The following is a description of a gene set: Human Gene Set: CAGCTG_AP4_Q5 from publication Xie X, Lu J, Kulbokas EJ, Golub TR, Mootha V, Lindblad-Toh K, Lander ES, Kellis M (PMID 15735639) Comprehensive identification of all functional elements encoded in the human genome is a fundamental need in biomedical research. Here, we present a comparative analysis of the human, mouse, rat and dog genomes to create a systematic catalogue of common regulatory motifs in promoters and 3' untranslated regions (3' UTRs). The promoter analysis yields 174 candidate motifs, including most previously known transcription-factor binding sites and 105 new motifs. The 3'-UTR analysis yields 106 motifs likely to be involved in post-transcriptional regulation. Nearly one-half are associated with microRNAs (miRNAs), leading to the discovery of many new miRNA genes and their likely target genes. Our results suggest that previous estimates of the number of human miRNA genes were low, and that miRNAs regulate at least 20% of human genes. The overall results provide a systematic view of gene regulation in the human, which will be refined as additional mammalian genomes become available. studied in species Homo sapiens Genes having at least one occurrence of the highly conserved motif M15 CAGCTG in the regions spanning 4 kb centered on their transcription starting sites. This matches the REPIN1 transcription factor binding site V$AP4_Q5 (v7.4 TRANSFAC)., and this is the list of marker genes: ZNF593, TNNI2, BMP6, ZFP36L1, MARK2, RUNDC1, AP3D1, SBSN, DLEU1, ZFYVE1, AQP5, FZD9, ARF4, TMEM104, CD72 (NCBI Gene Id 971), NPHP4, ATP1B4, MRGPRF, SLC35A4, ZBTB20, CD99L2, CLEC4D, LRRN2, CAST, ATXN7L2, MAN2B1, MEGF10, RPUSD4, MYCLP1, TBCC, ABHD16A (abhydrolase domain containing 16A, phospholipase), FOXS1, MUSK (muscle associated receptor tyrosine kinase), ERH, ANXA8, HDAC4, HCFC2, MT1E, SOX10, GRIN2D, PKD2L1 (polycystin 2 like 1, transient receptor potential cation channel), SKIDA1, NDUFA4, ACMSD, CELA3A, LINC01567, LENG9 (leukocyte receptor cluster member 9), ADCY4, CREM, NSG2, GPX1, MYH13, IL11, KLF10, PURA, BRSK2, SNN, HIP1R, NR2E1, LEMD2, DHRS3, FAM222A, RAB3A, LY6G6E, BRINP1, KCNN2, MYO1C, NAGLU, ARPP21, ITSN1, SGK2, PYGM, MITF, RNF14, KCNH2, PPP1R7, NXPH3, MAP3K13, DLL4, HIVEP3, DLGAP1, RAB33A, CNTN4, CELF3, EGR1, SPEG, USP13, PTPN6, STAT3, CTXN1, APOA5, LNX1, ACTN3 (actinin alpha 3), CAVIN2, ST8SIA4, NEURL1, SEMA6D (NCBI Gene Id 80031), TMEM182, HMOX1, CA3 (carbonic anhydrase 3), IGF1, GREB1L, ITGA6, PRICKLE2, WDR83, FXYD3, RENBP, TP53INP2, UBE2B, AGBL5, CNTN6, BTBD3, ATP6V1C1, MYCBP, SLC39A9, FXR1, PCYT1B, SRP54 (signal recognition particle 54), PRMT6, DTNA, GRIK3, IL11RA, ERN1, TNNC2, RYK, ARHGAP44, NTS, NOTCH1, WNT10B, FREM1, EMILIN3, IRAG1, EGR2, MOSMO, HTR3A, CLEC14A, ZMYND8 (zinc finger MYND-type containing 8), ASB16, DPF2, LBX1, ASB2, BACE2, NID2, LRRN1, ITGB1BP2, MAST1, DDIT4L, TMEM86A, SLC4A1, EBNA1BP2, LONRF1, ITGA3, USP32, AZIN1, FOXO4, IGFBP3, FOXP1, LINC00670, TXNDC12, TSC22D4, SYTL2, BNIP3, ZNF385A, YWHAZ, PAK3, DOCK6, PAM, YY1AP1, KLF13, MAPRE3, ZNF703, PATL1, DYSF, CPA6, PLS3, SCFD1, MORC3, TRIM8 (tripartite motif containing 8), LRRN3, APBA2, FCGBP, PLCB2, JAG1, FAM110A, FAM193A, E2F1, RBFOX1, FHL3, C1QTNF1, TNKS1BP1 (tankyrase 1 binding protein 1), GTPBP2, SRD5A3, TPM3, NXPH4, HSPB6, AMER1, ARID1A, HSPB2, SEZ6, CTSD, LINC02875, UBR5, MXI1, OLFML1, PCDH18, FOXD3, DCLRE1A, TMUB2, SPOP, HOXC6, DRP2, KMT2A, WDTC1, MSS51, SEMA7A, H2BC3, MYO1F, FBXO40, RHOBTB2, PPP2R5E, FGF17, TGIF1, DUSP26, MPRIP, GOLGA7, ALK, SLITRK6, ARHGAP45 (NCBI Gene Id 23526), SUPT16H, DPH1, ZFYVE26, IGFBP6 (NCBI Gene Id 3489), NTF4, BBLN, BCL6B, HJV (hemojuvelin BMP co-receptor), SYNRG, TXN, TUBB2B, ZFAND3, CFAP65, CDK2, SYT6, WNT6, CYTH3, AFG3L1P, TAS1R1, S100A2 (S100 calcium binding protein A2), ZNF384, SPRED1, CSMD3, BAZ2A, GRPR, PIGN (phosphatidylinositol glycan anchor biosynthesis class N), PSIP1, LRBA, EYA1, ERP27, RPS6KB1, HTR5A, ZNF326, TINAGL1, RAD51B, ADCY8, GPR37L1, TCF12, WNT2, ACTA1, SLC35C2, CLVS1, CRHBP, NDRG1, MYL3, PCF11, CDKN3, CDX1, MAP3K8, LGI4, LMF2, PTK7, ENO3, ANKZF1, PRKAG3, NBEA, CREB3L1, BTG2, ESCO1, ID3, DPP3, SCRN1, TBC1D2B (TBC1 domain family member 2B), ESRRA, SERPINE1, MASP1, DNHD1, GPM6B, NGF, IP6K3, GNB3, SULT2B1, CNP, WNK4, NR4A1 (nuclear receptor subfamily 4 group A member 1), DOC2A, AKR7A2, ZEB2 (NCBI Gene Id 9839), COLEC12, MYO18A, PRKCB, CACNG2, SLC25A41, LTBP1, ATP6V1E2, MOSPD1, HMGA2, PARP12, PAK5, TPMT, NFIX, ZBTB16, SNPH, LGI3, LGSN, LRRN4CL, SHISA6, RNF121, CD247, REPS1 (NCBI Gene Id 85021), TNFSF4, ZNF232, DMPK, PPAT, MCF2, NCDN, TMEM125, CDK5R2, BMPR2, SPRY4, HOXA6 (NCBI Gene Id 3203), SH3BP1, PADI2, YBX2, HID1, IFNL2, PAICS, NAT9, LHX2, RAD51D, RPL28, C11orf87, CARMIL3, SLC1A7, CDC25B, TAPT1-AS1, PODN, P2RY4, HIGD1B (HIG1 hypoxia inducible domain family member 1B), GAS7, REEP6, RIMS1, NEB, ARHGAP33, DPP9, BACH2, SLC38A3, NTF3, KLK2, NLGN3, HIP1, WNK2 (WNK lysine deficient protein kinase 2), ABR, VXN, COA3, PRDM8, DLL1, SEMA4A, ANK2, OGG1, TONSL, CABP1, SLC25A26, ARHGAP8, GABPB2, EIF2S1, PASK, STAT2 (signal transducer and activator of transcription 2), FILIP1, YARS1, F11R, RNF216, SLC5A10, FOXA1, KLHDC7A, ZMYM2, ATF7IP, DDX5 (DEAD-box helicase 5), PPM1J, HSH2D, XBP1, ABHD4, PDGFB, GPR62, APLN, GCAT, TRIP11, NOVA1, EXOC6, MIR9-1HG, RGS8, HOXD10 (NCBI Gene Id 3236), CRMA, ANXA6, JMJD1C, CCL4, STAT5A, ARL6IP5, CNTN2 (contactin 2), CUL7, RTKN, SLC8A3 (NCBI Gene Id 90450), KDM2A, S100A3, CMKLR1, IL17B, SRF, CALM3, ZBTB25 (zinc finger and BTB domain containing 25), LRRK1, OGFOD2, KSR2, TMEM35A, SEPTIN4, PCDH9, PHKA1, PIK3CG, TIMP4, WWC2-AS2, ADAMTS8, ERBB3, MANBA, OSR1, HNRNPDL, UBALD2, HOXA3, PGF, MAF, FER1L6-AS1, CCL27, MYL6B, ANKRD12, SYNPO2L, IL10, FLRT3, TUBA8, INHA, MYT1, MID1, IRX4, SH2D6, EPHA2, IL24, ADAMTS4, MYOZ1, SH2B3, PDZD11, PRKACG, CDH6, NR4A3, SCAP, PDE1A, GPD1, KCNJ16, SYVN1, ATP1B2, KCNJ13, PLN, PLEC, MYF5, RAB24, OMG, CORO2B, ETV5, HOXC4, LDLRAD3, NECTIN3, DALRD3, ATP4A (ATPase H+/K+ transporting subunit alpha), FBXO36, HHATL, KCNS3 (NCBI Gene Id 3790), CMKLR2, NOL4, UBE2W, PTH1R, CDKN2C, PLAAT3, ZNF398, PLEKHA6, EIF4ENIF1, UNC119, C7, PBXIP1, CLDN15, KCNMB3, GAP43, TTLL7, HHEX, MGLL, RAPSN, ZNF646, NANOS1, GIGYF2, RAI1, PPP1R17, PSD, SLC12A8, FAM98A, QTRT2, TSC22D3 (NCBI Gene Id 64477), MRPL14, RNF166, KCNQ5, PROSER3 (NCBI Gene Id 148137), LUC7L3, OMA1, L1CAM, WDFY1, TRMT10A, PDHA2, MAP2K5, TBX3, DOCK9, RNF213, SYT16, VEGFA, RABAC1, MATN1, ARMC8, ZNF277, KLHL1, RTN2, SELPLG (selectin P ligand), MTIF2, CDC42SE1, PTGDS, SPPL3, POLD4 (NCBI Gene Id 57804), COL7A1, TCF7, MFNG, MUC15, PHF7, ZSWIM8, ABL1, TNNT3, RIBC2, ZNF777, SCUBE3, CITED2 (Cbp/p300 interacting transactivator with Glu/Asp rich carboxy-terminal domain 2), RELA, LGI1, AGAP2, NDUFC1, GPR174, LCK, AAK1, MED13, SCN4A, B3GALNT2, GNG3, SMARCA2, HRAS, CHID1, ASPA, SMAP2, SPATA31H1, TGFB3, MYADM, RIPOR1, MTSS1, TSPAN33, EN1, RGS6, DRG1, NUDT22, TAL2, ELF4, MYO18B, SRPX, BCL11B, DES, GFI1, MAN1C1, GRHL3, PEX7, MYBPC1, RGR, DDIT4, VEZF1, TRIM39 (tripartite motif containing 39), E2F3 (NCBI Gene Id 1871), ZMIZ1, XIRP1, DDX17, ADGRL3, CERKL, RHBDF1, PLPP7, LINC00487, PPP3CB, RUSC1-AS1, SAMTOR, KCNMA1, MYCN, RASSF2, ADGRG4, WDR25 (WD repeat domain 25), TNNT2, RASSF1, TNFRSF19, SLC44A2, TGFBR2, EPCIP, TMOD4, BEST2, CLPS, RAB27A, AKT2, RRAD, GABRA3, FBXO24, YTHDF2 (NCBI Gene Id 63042), FGF14, EXTL1, TRAPPC3, FAM120B, FGF12, NCKAP5, TENT5C, KLF5, ELL3, CAPZA3, SLC22A17, C6orf47, IMPDH1, TRPV1, REEP1, FBXL21P, USP1, TMEM126B, CCDC138, UBE2H, SCT, GEM, OPCML, GPR162, SUPT5H, FMO5, SLC4A2, TRIT1, CEP95, RFX8, LBX2-AS1 (LBX2 antisense RNA 1), ASS1, GPR21, NRG2, TOLLIP, MID2, GOLGA2P11, TFAP4, SYNC, COX6A2, NDUFAF3, FAM193B, SLF2, HPSE2, RPL23AP32, NTNG2, RTL9, CIBAR2, CHRNA1, HTR2C, ANKRD1, SRCIN1, NRK, RUNX3, FITM1 (fat storage inducing transmembrane protein 1), FGF7, STOML2, IL1RAPL2, CBFA2T3, PDE3A, RAB5B, ELAVL2, TRERF1, INF2, GPBP1, GJC2, MTMR10, VAT1, TOB1, ABTB3, ASIC2, PVALB, KCNIP3, PITX3, ATP2B3, EPOR, ABLIM1, CNNM2, ANGEL1, SOX2, TRAF3, LOXL4, B3GALT2, APBB3, ONECUT2, SPECC1, GATA1, ZMAT3, NCAPH2, GRIN2B, ARFGEF1, DLG2, HYAL2, ARHGEF6, TGFB2, CDHR5, FEZF2, CSF1R, RAP2B, COMMD3, ZNF710, PLCZ1, SLITRK5, LRCH4, MDK, WNT9A, PAX1, KCNQ4, FIS1, SV2A, GOLM2, DACT1, CHPF, MARCHF1, SPINK5, IDH2, MAP2K6, NDST4, NAPEPLD, TPCN1, CDKL5, POU4F1, HS3ST4, HSD3B7, JPT1, NEDD4, CALCOCO1, LHFPL1, TFAP2C, BTF3P11, TUBA4A, ACSL4, SEPTIN3, RASGEF1A, MAPK4, RTRAF, EOMES, PEPD, LNX2, TNS1, DCX, GPR34, KCNA2, MARCHF5, CD79B, ZNF521, HMGN2, KLF8, SMARCA1, NDUFA4L2, CCDC43, SOX4, GADD45G, INSR, MAP1A, SSX2IP, ATG9A, SPIB, PARP8, ADAMTSL2, ID1, NKX2-2, CLDN2, DLEU2, TMOD3, SLC44A1, WBP1L, SPG21, TRIP4, ZBTB18, LINC03124, VSTM2A, PRICKLE1, LARP4, TRIM46, DYNLRB2, HES6, RAG1, DOK7, RRAGD, SPTAN1, CLIP1, KDM4C, FOXN2, RCOR2 (REST corepressor 2), KCNQ1DN, ERF, PHF23, HDAC9, LRP5, STXBP6, FAM131A, MAPK8IP1, ERLIN2, SGMS2, FGF13, TMEM25, MLIP, DAO, PNMA1, DUSP1, SOST, USF1, IFNL3, SMARCA5, ZMYM4, PPP1R9B, NHSL2, NUMBL, SRRM3 (NCBI Gene Id 222183), TPM2, MLLT11, TLNRD1, PDE7A, LINC01089, VWA5A, APOBEC2, TMEM17, PTCH2, IRF2BPL, PLXNB3, WNT4, NRBF2, SALL1, MCAM (NCBI Gene Id 4162), CASKIN2, KRTCAP2, SKA2, MBNL1, PLEKHA4, SMG5, CDKN1B, LAMA5, USO1 (USO1 vesicle transport factor), PRR30, AKT1 (AKT serine/threonine kinase 1), PTGFRN, BMF, PAK6, ALS2, SCN5A, GSK3B, BSCL2, TMEM184A, PLP1, OR2L13, WDR83OS, ADO, KLF12, H3C4, CA11, ATP6V1D, IMPG1, RUNX1T1, RAD51AP1, RERG, PEG10, IPCEF1, PDK2, EDC4, NEUROG3, RAB3C, CCDC78, WDPCP, DLL3, SPTBN1, TNNT1, UBE2O, ESRRG, TRIM54, CKM, AP5M1, PPP1R16B, TUBA1A, CDH3, TRPC4, MTMR4, SVIL, SMIM43, NAP1L5, HSPA5, PARP6, RCAN1, HSPB3, SIX5, IQCD, CACNB1, SOWAHA, ATP5PD, UFM1, PACSIN3, ABCB9, YPEL5, ARHGEF5, ETV1, MEF2C, CHAC1, PHF1, LINC00482, CDH13, CMTM5, UBTF, EPN2, ACE, MYBPH, BNIP2, CNTNAP5, RBMS3, VGF, ACTB, COL5A3, SMC1B, CHRNG, MOB3C, NDST2, PLAC1, TSEN54, DTX3, RDH10, CCDC65, ARHGAP24, APBB2, TMF1, ELAVL3, CILP, AQP2, CCDC186, PDLIM2, MEIS2, STIM1, SPTY2D1, RESF1 (retroelement silencing factor 1), LDLRAD4, GRK2, PTP4A3, XPR1, MPPED2, TMEM178A, SLC30A8, PTCHD1, SOBP, TPI1, NNAT, LHX3, DNAJC1, S100A8, MYL11, PRKACA, AIF1L, PPP2R3A, KCTD8, RNF19B, HDAC11, RARA, DMC1, PDLIM4, LGALS1, ISL1, MYOT, MAP3K5, BAP1, PSD2, MDM2, SPCS1, H2AZ1, STAR, CCNJ, CAMK2G, SMARCAL1, SLC66A1 (NCBI Gene Id 54896), HIF1A, CADM2, SAMD1, METTL8, EIF4G2, TRIM62, CCDC85B, CD276, CDO1, VAMP1, TENM3-AS1, ETS1, ACTC1, FGF8, RBM15B, KLK13, AKAP9, RHOD, VAMP3 (NCBI Gene Id 9341), PPP2R5C, HSD11B1, NIPBL, PRR35, TUSC2, ARMC5, EPN3, LRCH1, PIK3AP1, NOL9, KIRREL2, TMEM255A, NUDT18, NCF4, COL2A1, KCNN3, BORCS5, H2AC7, CAMKV, KRT19, APPBP2, DCAF17, RIN1, KIF4A, USP49, LHFPL2, CASK, ACVR1, TEX35, GRK5, STAT5B, CNIH2, ZNF503, KNCN, ART1, SLC1A4, CFAP57, EYA3, CUTA, MSTN, RETNLB, LIMK2, GATA3, CRACR2A, RNF13, SLC7A11, CYP2F1, DMD, AFF4, TRPM4, ZNF267, ZBTB33, MYOZ2, MYOZ3, SORBS3, TCF21, ETF1, PCBP4, WNT10A, VPS18, TLE4, AMOT, IZUMO4 (NCBI Gene Id 113177), BNC2, FCER1G, BRINP3, FGF1, FES, GASAL1, PSMD3, COL22A1, AARSD1, APOLD1, SLC29A4 (NCBI Gene Id 222962), SLC5A7, NAV1, BRD4, TMEM105, MEF2D, SPOCK2, PHLDB1, PRKCQ, CHD4, SLC43A3, NAA50, SLC18A3, PRPF39, TFDP2, ELN, MAGED1, CXXC4, TAFAZZIN, INA, MYPN, RASL10B, REPS2, RUFY1, DBNDD1, PDAP1 (PDGFA associated protein 1), UGT1A7, IGF1R, BCL7A, MAP3K3, GNB2, TPPP3, CBFA2T2, SUV39H2, RGS7, DAAM1, H2BC7, PTGIR, PREX2 (phosphatidylinositol-3,4,5-trisphosphate dependent Rac exchange factor 2), CRYAB, SMYD1, ARNT, INKA1 (inka box actin regulator 1), KLHDC2 (kelch domain containing 2), BAHD1, PML, VGLL3, BAIAP2, TMEM100, MIR137HG, ROBO4, KCNJ2, OBSCN, SH3BGRL3, ANP32A, GPR17, DLX1, RXRG, ZNF133, DENR, FBXO5, BEND4, IL34, CACNA1S, MINDY1, LUC7L, SLC12A2, FGR, MCOLN1, TEAD2, KIF7, RAB26, NACA, WBP2NL, SGCG, PRRG2, GZMB, BEX2, EYA2, ELP4, BACH1, DVL3, FCRLB, PRR14L, SOX5, BCL9L, SPAG6, ALDH1A1, ARHGEF2, LRRTM1, ITGB8, PTK2, CNTD1, ESR1, USP5, SRPK3, TUBB4A, NPPA, MBP, CD47, LRRTM3, SLC26A10P (solute carrier family 26 member 10, pseudogene), LEF1, SUMO2, MYLK, KCNIP2 (potassium voltage-gated channel interacting protein 2), TMEM109, MMRN2, IMMP1L, PRDM13, SPATA6, KLHL40, SOX12, ANGPT1, KLHL41, WNT2B, ANKRD20A11P, POLL, KCNK5, CATSPER2, POLR3GL, APOD, TUG1, CSNK1G2, CPEB3, STMN2, VAMP8 (vesicle associated membrane protein 8), MEGF8, CCDC26, HOXB1, CCDC102A, MOS, TRAF4, SUMO4, NOL4L, USP32P2, MYH4, EFNA1, CRB1, CAV3, CACNA2D3, NADK2, MYO7A, NR5A1 (NCBI Gene Id 2516), P2RX4, PRR11, PTPN1, LRFN5, FERRY3, HOXB5 (homeobox B5), ABTB2, PTPRS, TUBA4B, HSD17B8, FCRLA, GGNBP2, ATP13A4, ALPK2, MACROD1, FAM50A, LINC00299, ZNF513, RASGRF2, CRIP2, SGIP1, SYTL1, KCNE4, EPHB2, CRCT1, LURAP1L, ORMDL3, NDNF, LMOD3, FGF21, FAM217B, CDK18, RUNX1, SHOX2, NUTF2, WNT8B, WNT7B, BCL2L2, PABPC5, CSDE1, TCF4, CALCA, LOXL1, C11orf52, GAB2, FAAP100, MOG, ACTG2, ESRRB, TBX6, SPIN2A, STAC3, PJA2, MIR22HG, LDB3, ITPR3, LINC00303, RUFY4, ABCE1, USP3, MFRP, NEXN-AS1, SRC, XCL2, DSCAM, ATP6V0D1, DNAJA1, TGIF2, USP54, EDF1, LTA, XPNPEP1, DPCD, UNC45B, ANGPT4, CHFR, KIF1B, TNRC6C, TRPT1, CACNB2, LINC02872, TNNC1, TOR1AIP1, ATP6V1A, THPO, RYR1, NEUROD2, DBH (dopamine beta-hydroxylase), C6orf62, PRKCG, DDR1, CACNA1H, CADPS, CLSTN2, MIR1-1HG, PPM1A, APBA1, STARD13, RIT1, CPS1, MBNL2, FRAS1, NAV3, CCDC177, ROCK1, PALMD, ATP1A2, PROK2, MAGI1, SYT17, EXTL3, WDR81, JPH1, RBBP7, LRP1, PMEL, BCAS3, CD9, FNDC8, DEPTOR, PI4KB (phosphatidylinositol 4-kinase beta), SLC6A14, CPEB4, RORC, CXorf58, SET, IKZF2, LMO4, CDK5, INPPL1, TP53BP1, SHISA4, FNDC5, SNCG, RNF111, OTUD7A, GNG8, LAT, CYP46A1, ELL, DCTN1, HAPLN2, P2RX5 (purinergic receptor P2X 5), LINC01138, H1-0 (NCBI Gene Id 3005), CACNA1G, HRC, DLC1, BICRA, CHRNE, MYC, EXOC5, AICDA, CCNE2, NOSIP, GSDMA, ATOH8, RGS12, LAMB2, HECTD2, HOXD3, RAMP2, RBM14, SLC24A3, ZNF668, GDNF, DNAJB5, PCBP2, KLK1, AP1S2, C7orf33, ASB5, GPR61, TUBG2, HOXA5, CHAT, RSRC1, EDN3, MAN1A1, TMT1B, SEPTIN7, POLR1D, CDCA3, IER5L, HPCA, DUSP4 (dual specificity phosphatase 4), DERL3, MLYCD, BMP1, ADGRB3, NES, TMEM79, MYBL2, ZRANB1, ANGPTL2, ABI2, VPS45, PDE10A, RBFOX2, NHLH2, DOCK4, NKD1, TMEM8B, CASKIN1, KCNS2, RCSD1, SCAMP5, APOO, HOXC12, DMTF1, FLNC, NEDD4L, GHR, LINC01931, ANK1, RPA3, KIFC3, HOOK1, CDC42EP3, DOK3, RASL10A, NR3C2, SERF2, ADAMTS2 (ADAM metallopeptidase with thrombospondin type 1 motif 2), PMP22, SSC4D, CCDC71, P3H3, CDK2AP1, WBP4, RAB30, ZCCHC24, EMP3, UBE2K, PAX2, PICALM, BFSP2, SCN3B, SORBS1, EFS, MYH3, CYP8B1, C1orf116, PCNX1, APP, ASB14, FRMD5, PRKAA2, ANAPC10, UNC13B, TRAM1, LRTM1, CBX6, JAKMIP3, PPP1R3D, BARX2, CCDC191, KCNMB1, LMF1, CSRNP3, OSBPL10 (oxysterol binding protein like 10), BTG1, LSP1, NHLRC2, TEF, UBE2D3, TACC1, LZTS2, CCND2, ADRA2C, TAPT1, FAM178B, NRP2, LAYN, NAPB, CXCR5, AMPH, JAKMIP2, BCL6, CALM2, RASL12, PPM1E, GOLPH3L, PNOC, RSPO2, MFSD2A, CHRD, PPP3CA, H3C3, MRPS6, BEST3, TBR1